Given this list of marker genes TMED3, SCN10A, BAIAP2L2, COPA, AP3S2, COPZ2, NCALD, COPB1, TMED7, AP4E1, SEC24D, DIPK2A, VPS33A, COPB2, SEC23A, SEC24C, COPG1, AP3B2, CHMP2A, STON2, AP1G2, CLTC, EPN3, AFTPH, EPS15L1, PICALM, MYCBPAP, CLTB, AP2A2, AP2B1, AP4M1, AP1S1, CHMP1B, TBC1D5, ARCN1, AP2A1, AP2S1, AP3M1, KLHL12, SYNRG, CIDEB, IGF2R, SEC23B (SEC23 homolog B, COPII coat complex component), CLTA, AP1S3, SYNJ1, SEC31B, CLTCL1, PDCD6, STON1, CHMP4A, AP5Z1, AP1M2, CLBA1, AP3S1, EPS15, AP1S2, AP1M1, SAR1A, CHMP4B, SGIP1 (NCBI Gene Id 84251), ARL6, AP4S1, CLINT1, SCLT1, AP1B1, SEC31A, KCNQ5, NECAP2, PEF1, SAR1B, SEC13, EPN1, NECAP1, AP4B1, AP3B1, EPN2, VPS39, AP3D1, AP1G1, COPE, COPG2 (COPI coat complex subunit gamma 2), SCYL1, AP5B1, VPS18, VPS41, SEC24A, AP2M1 (adaptor related protein complex 2 subunit mu 1), AP5M1, AP5S1, SLC18A3, COPZ1, ENTHD1, SEC24B, BTBD8, AP3M2, here is a description of the gene set: studied in species Homo sapiens Any of several different proteinaceous coats that can associate with membranes. Membrane coats include those formed by clathrin plus an adaptor complex, the COPI and COPII complexes, and possibly others. They are found associated with membranes on many vesicles as well as other membrane features such as pits and perhaps tubules. Human Gene Set: GOCC_MEMBRANE_COAT